The following is a description of a gene set: studied in species Homo sapiens Neurotransmitter clearance Human Gene Set: REACTOME_NEUROTRANSMITTER_CLEARANCE, and this is the list of marker genes: SLC22A1, ALDH2, BCHE, SLC6A3, LRTOMT (leucine rich transmembrane and O-methyltransferase domain containing), COMT, ACHE, SLC6A4, LRRC51, SLC22A2, MAOA